Given this list of marker genes HSPG2, ACBD6, UFD1 (ubiquitin recognition factor in ER associated degradation 1), MS4A1, DEAF1, NLRP12, IKBKB, SALL4, SEC61A1, IL7R, NFKBIA, NME8, CFI, SGSH, GAS2L2, IGKC, LCK, MST1R, GNS, FOXN1, RSPH4A, MYSM1, TCOF1, GLI3, HPS6, NOTCH2NLC, TBX1, RAG1, POLD1, IDS, IRF2BP2, NME5, DOCK8, TNFRSF13C, ZAP70, ARID1A, ARHGEF1, ICOS, DNAAF4, DNAAF2, SRP19 (signal recognition particle 19), P4HA2, RELB, SMARCE1, HIRA, CREBBP, STXBP2, SMARCA4, JMJD1C, USP9X, SERPING1, DPF2, FLII, SOX9, USB1, NAGLU, GFI1, BRWD1, HYOU1, DNAAF5, COG4, RREB1, XIAP, DNAAF6, JAK3, HYDIN, STX3, IFIH1, DKC1, ZMYND10, HLA-DRB1, CARMIL2, TERT, SMARCD1, IQSEC2, BLM, TP53, PRKCD, RFXANK, STK36, POLD3, RTEL1, MDM4, F12, MDFIC, COMT, MGP, MAGT1, HLA-B, IVNS1ABP, SCNN1G, WAS, SOX11, IL17RA, NFKB2, G6PC3, CFAP74, SPAG1, MBTPS2, STAT1, PTPN22, DNAAF1, MCIDAS, DNAAF11 (dynein axonemal assembly factor 11), ZBTB7A, CIITA, RNF168, KDM5C, AICDA, ACP5, TINF2, ADNP, CD81, LRP12, WRAP53, GP1BB, RAI1, TBC1D24, LEP, TMCO1, TBK1, CTC1, OFD1, CXCR4, LEPR, ODAD2, EP300, IKBKG, ASAH1, NCF4, RILPL1, CTLA4, PSMB8, SLC29A3, DNAH5, GIPC1, PLG, PLP1, FOXJ1, PLVAP, SLC37A4, GLB1, SH3KBP1, GUSB, DCLRE1C, ZNF341, SPI1, LRBA, SH2D1A, SASH3, PHIP, PIK3R1, HGSNAT, ARID2, STK11, PNP, ZBTB24 (NCBI Gene Id 9841), RSPRY1, CR2, CD19, SOX4, TNFSF12, MID1, TNFRSF13B, GNPTAB, TYMS, UQCRH, STK4, RAC2, IL21R, NEK10, ARSB, SMARCC2, SCNN1A, UNG, IGHG2, FCGR3A, COL5A1, C4B, DNAJB13, CORO1A, ARID1B, ELANE, NOP10, RAG2, CD4, FOXP1, NFIX, NFKB1, HLA-DPB1, DNAI2, TNFRSF1A, ADA2, KATNIP, SCNN1B, MGAT2, ODAD1, PARN, SHH, DYM, STAT3, GALNS, MATR3, SETBP1, ICOSLG, RSPH1, SEC24C, PDE11A, CLPB (ClpB family mitochondrial disaggregase), IGHM, PRPS1, UNC119, HCK, IL6ST, CCDC65, CFAP298, BTK, RNH1, NPM1, ARVCF, XPNPEP2 (X-prolyl aminopeptidase 2), PIK3CD, ALMS1, NHP2, TNFRSF9, PRKAR1A, SLC4A10, TCIRG1, ADA, COL5A2, PTEN, KRT5, IL6R, SMARCB1, ALG12, POLE, TERC, TP63, GJA1, here is a description of the gene set: Abnormality of the pharynx studied in species Homo sapiens Human Gene Set: HP_ABNORMALITY_OF_THE_PHARYNX An anomaly of the pharynx, i.e., of the tubular structure extending from the base of the skull superiorly to the esophageal inlet inferiorly.